The following is a description of a gene set: Any process that modulates the potential difference across a presynaptic membrane. species: Homo sapiens Human Gene Set: GOBP_REGULATION_OF_PRESYNAPTIC_MEMBRANE_POTENTIAL, and this is the list of marker genes: GABBR1, KCNJ3, GRIN2D, KCNQ5, GRIK5, HTR3A, KCNC2, CASR, KCNJ9, GABRA5, SCN10A (sodium voltage-gated channel alpha subunit 10), KCNA2, GRIN3B, SCN1A, KCNC1, GRIK3, GRIA1, KCNJ8, GRIN2B, GABRB1, GABRR1 (NCBI Gene Id 2569), GRIA3, GRIK4, KCTD16, KCNJ11, KCNA4, KCNMB4, GABRA2, GRIK2, GLRA1, GRIA4